Given this list of marker genes Luc7l3, Ugt2b37, Inf2 (inverted formin, FH2 and WH2 domain containing), Tubb6, Gc, Orc4, Ckap2, Tmem202, Mre11a, Kctd18, Nfkbia, Kcne2, Txndc9, Lrrc55, Nxpe5, Zfp260, Zfp36l2, Clcn6, Cdadc1, Zfp696 (NCBI Gene Id 319792), Actrt2, Nexmif, Zfp710, Ptger2, Reck, Rbl1, 1700031F05Rik, Ugcg (NCBI Gene Id 97164), D030056L22Rik, Chn1, here is a description of the gene set: Mouse Gene Set: MIR_3102_5P.2_5P species: Mus musculus Genes predicted to be targets of miRBase v22 microRNA mmu_miR_3102_5p.2_5p in miRDB v6.0 with MirTarget v4 prediction scores > 80 (high confidence targets). from publication Chen Y, Wang X (PMID 31504780)